The following is a description of a gene set: Genes up-regulated in comparison of naive CD4 CD8 T cells versus unstimulated NK cells. species: Homo sapiens from publication Abbas AR, Baldwin D, Ma Y, Ouyang W, Gurney A, Martin F, Fong S, van Lookeren Campagne M, Godowski P, Williams PM, Chan AC, Clark HF (PMID 15789058) Immune cell-specific expression is one indication of the importance of a gene's role in the immune response. In order to identify such patterns, we set out to broadly profile gene expression in a variety of immune cells. Human Gene Set: GSE22886_NAIVE_TCELL_VS_NKCELL_UP, and this is the list of marker genes: PRORP, CD3G, FCGRT, FLT3LG, KBTBD4, UXS1, CBR3, RGS10, LDAF1, VIM, GPSM3, LRRN3, CCR7, LIME1, DPP4, RPS29, TNFRSF10B, HDHD3, SRP14, PRKCA, CD3E (CD3 epsilon subunit of T-cell receptor complex), EPS8L2, BCAT2, GPRASP1, RIOX2, TRBC1, LEF1, WDR74, MALT1, CSDE1, AKAP1, CCNE1, UXT, ERGIC3, SORBS3, SIN3B, RPL26, TLE5, TNFSF8 (NCBI Gene Id 944), MPI, UBASH3A, PHF1, PLEKHB1, KCNN4, PLPP1, TACC3, IDH3A, IFRD2, PABPC4, DHPS, FABP6, ENO2, LPCAT3, SYPL1, ANP32B, SNHG20, NDFIP1, MAP4K2, AIP, TOMM20 (NCBI Gene Id 9804), LRCH4, NCK2, PALS2, TTC9, SPINT2, LRRC8B, PSIP1, ABCC1, LYRM4, EIF3E, PKIA, CREBL2, ZC3H14, LDHB, RSL1D1, EIF3H, CAD, OXA1L, RPS10P5, TMEM204, RPL8, NOSIP, STAT5B, EIF3D (NCBI Gene Id 8664), MAL, ACTR1B, SMYD5, ITK, TRAC, CCNG1, LY9, PLGRKT, RETREG1, RPS10, RIOX1, DXO, HIGD2A, BCL11B, JHY, SYNE3, GRSF1, LEPROTL1, SCMH1, COX11, CD3D, TAF9, HBS1L, NENF, LRPPRC, SEC31B, EIF2D, DGKA, SNU13, PASK, ODC1, TMEM63A, CD5 (CD5 molecule), SMARCB1, DAP3, RPS6, OSBP2, TOMM22, ACVR1, ASXL1, AQP3, RIC3, AMD1, PLP2, CCNB1IP1, RPL19, CASP6, RPL10L, ZNF580, ESD, ERP29, RPL36, FKBP5, FBLN5, ARHGEF18, RGS14, PDCD4-AS1, ID3, PAFAH1B3, SLC2A4RG, SARAF, RPL10, RNF144A, VIPR1, UPK2, ACAP1, LRFN3, PBXIP1, PRKRA, CNN2, CCDC59, PABPC1, GCFC2, IL7R, DNAAF5, ADK, DNAJB1, SF3A2, RPS3, IMPDH2, CNIH1, CD27, THAP4, MYC (NCBI Gene Id 731404), ADARB1, MCUB, TNFRSF10D, ST13, SIRPG, CDR2, CEP68, RPL22, TOB1, PEBP1, IPO4, RPL35, LTB, SLAMF1, SLC16A10, LHPP, ITM2A, ATP6V1B1, MSL3, RHOH, MDFIC, LDLRAP1 (low density lipoprotein receptor adaptor protein 1), GRPR, ARHGAP15, CD28, TBX2, TBC1D4, INPP4B, NELL2, GLI2